The following is a description of a gene set: studied in species Mus musculus Mouse Gene Set: GOBP_TELOMERIC_LOOP_FORMATION The process in which linear telomeric DNA is remodeled into duplex loops, by the invasion of a 3' single-stranded overhang into the duplex region., and this is the list of marker genes: Terf2ip (NCBI Gene Id 57427), Dclre1b, Terf1, Pot1a, Terf2